The following is a description of a gene set: species: Mus musculus Mouse Gene Set: chr8C4, and this is the list of marker genes: Fto, Gm8489, Aktip, Tox3, Gm36243, Chd9, Gm19935, Rbl2, Gm6658 (NCBI Gene Id 635070), Gm22428, Rpgrip1l, Gm35963